Given this list of marker genes Fcgr1, Syk, Igkv1-110, Ighv7-2, Ighv12-3, Ighv5-12-4, Ighv13-2, Ighv8-5, Ighv3-6, Ighv3-8, Fcgr2b, Igkv20-101-2, Ighv3-5, Src, Ighv5-9-1, Cd3g, Ighv7-4, Ighg2c, Ighv6-7, Ighv8-13, Igkv1-133, Igkv2-137, Igkv2-112, Igll1, Ighv5-12, Igkv1-117, Ighv8-2, Igkv17-121, Fcgr4 (NCBI Gene Id 320130), Ighv5-4, Ighv6-5, Ighv16-1, Hck, Ighv3-1, Ighv5-17 (immunoglobulin heavy variable 5-17), Ighg1, Ighv6-3, Ighv5-2, Igkv18-36, Igkv1-122, Ighv7-3 (immunoglobulin heavy variable 7-3), Igkv11-125, Ighv8-6, Fyn, Ighv5-15, Igkv1-135, Ighv3-3, Ighv5-9, Cd247, Ighv8-9, Ighv3-4, Igkv1-131, Ighv5-6, Yes1, Ighv6-4, Ighg3, Igkv1-132, Ighv6-6, Igkv15-103, Igkv1-35, Iglc1, Igkv16-104, Ighv8-12, Igkv2-109, Igkv1-99, Ighv8-8, Lyn, Igkv8-21, Ighv8-11, Fgr, Ighv8-4, Ighv5-16, Igkv1-88, Iglc2, here is a description of the gene set: Mouse Gene Set: REACTOME_FCGR_ACTIVATION FCGR activation species: Mus musculus